The following is a description of a gene set: Human Gene Set: KEGG_MEDICUS_REFERENCE_MEVALONATE_PATHWAY studied in species Homo sapiens Mevalonate pathway. Pathway ID: N01635. Pathway type: Reference. Pathway class: nt06034 Cholesterol biosynthesis. Pathway Definition from KEGG: Acetyl-CoA -- ACAT >> HMGCS >> HMGCR >> MVK >> PMVK >> MVD >> IDI >> (FDPS,GGPS1) -> Farnesyl-PP, and this is the list of marker genes: IDI1, FDPS, ACAT2, HMGCR, HMGCS1, ACAT1, GGPS1, IDI2, MVD, MVK, HMGCS2, PMVK